The following is a description of a gene set: Any process that modulates the frequency, rate, or extent of myeloid cell apoptotic process. Human Gene Set: GOBP_REGULATION_OF_MYELOID_CELL_APOPTOTIC_PROCESS species: Homo sapiens, and this is the list of marker genes: MEF2C, SELENOS, CCL5, ITPKB, KITLG, EPO, APOH, BCL2, ANXA1, FCAR, ADIPOQ (adiponectin, C1Q and collagen domain containing), MAEA, HCAR2, PIK3CD (phosphatidylinositol-4,5-bisphosphate 3-kinase catalytic subunit delta), CCR5, PIK3CB, SNAI2, GHSR, GATA1, ADAM17, SIRT1, CDKN2A, STAT5A, GAS6, STAT5B, NOD2, SLC7A11, NF1, MIF, CLEC5A, FCER1G, MIRLET7B, THRA, IRF7